Given this list of marker genes Wnt10b, Mef2c, Gja1, Phex, Sost, Fgf23, Prkaca, Fos, Cited1, Kat2b, Itga2, Hdac6, Gnas (GNAS complex locus), here is a description of the gene set: Any process that results in a change in state or activity of a cell or an organism (in terms of movement, secretion, enzyme production, gene expression, etc.) as a result of a parathyroid hormone stimulus. Mouse Gene Set: GOBP_RESPONSE_TO_PARATHYROID_HORMONE species: Mus musculus